The following is a description of a gene set: species: Mus musculus Mouse Gene Set: GOBP_T_CELL_HOMEOSTASIS The process of regulating the proliferation and elimination of T cells such that the total number of T cells within a whole or part of an organism is stable over time in the absence of an outside stimulus., and this is the list of marker genes: Ppp2r3c, Lmo1 (NCBI Gene Id 16908), Siva1, Fas, Tcirg1, Il20rb, Spns2, Il7r, Stat5b, Gpr15lg, Akt1, Prdx2, Il2, Stat5a, Ccnb2, P2rx7, Tsc22d3, Slc46a2, Cd24a, Foxn1, Zc3h8, Aim2, Tgfb1, Nckap1l, Gpr174, Ppp2ca, Bax, Rag1, Rc3h2, Lgals2, Tnfsf4, Dnaja3, Tgfb2, Gpam, Ripk3, Rc3h1, Gimap5, Ppp3cb (NCBI Gene Id 66215), Casp3, Ahr, Pmaip1, Rps6, Tnfrsf4, Slc39a3 (NCBI Gene Id 208667), Ppp2r1a, Bcl2l11, Cd47, Sit1, Coro1a, Bcl2, Jak3, Il2ra, Fadd, Chst3, Gimap3